The following is a description of a gene set: from publication Bedogni F, Hevner RF (PMID 34321999) Genes selectively expressed by postmitotic projection neurons in the cortical plate of embryonic day 14.5 mouse cortex. studied in species Mus musculus Mouse Gene Set: HEVNER_CORTICAL_PLATE_POSTMITOTIC_PROJECTION_NEURONS, and this is the list of marker genes: Atl1 (NCBI Gene Id 73991, atlastin GTPase 1), Cotl1, Rasgrf1, Vrk2, Ryr3, Ndrg1, Cdh13, Nsmf, Hs3st4 (NCBI Gene Id 628779), Sox5, Mgll, Ssbp3, Chst1, Lrrtm3, Tle4 (transducin-like enhancer of split 4), Abtb3, Lpl, Stx1a, Dmxl2, Sema4f, Dact1, Sgip1, Prkag2, Med13l, Sema4g, Ldb2 (LIM domain binding 2), Rab3d, Acvr1c, Nub1, Ppp3ca, Dab2ip, Herc3 (hect domain and RLD 3), Neto2, Kcna1, Tmem150c, Bach2, Rab3c, Ptpro, Rspo3, Adamts3, Ifngr2, Camk2b, Tmtc1, Scn2a, Fosl2, Ina, Tusc3, Nr4a3, St3gal1, Gria3, Rbfox1, Slc29a4, Hspa12a, Pde9a, Tenm2, Gls, Klhl29, Sh3gl2, Zfpm2 (zinc finger protein, multitype 2), Nrg3 (neuregulin 3), Spast, Gnal, Rnf112, Pcdh9, Ptp4a1 (NCBI Gene Id 98792), Rtn4r, Lrfn5, Adcy1, Cacna1h, Sema7a, Tgfbr1, Hs6st2, Marchf4, Khdrbs2, Rbm24, Dyrk2, Efna3, Smarca2, Lrrtm4, Kcnj3, Kcnv1, Fabp3, Kcng1, Rnf182, Fat4, Brd9, Cemip2, Fat3, Eps8, Cbln1, Baiap2, Asic1, Ppp1r16b, Lnx2, Cblb, Dync1i1, Kit, Syt4, Fig4, Trak1, Rtn4rl2, St18, Klhl8, Mgst3, Morn4, Adcyap1 (NCBI Gene Id 11516), Robo1 (NCBI Gene Id 436378), Sez6l, Pcnx1, Tnik, Sv2b, Slc8a1, Cnih3, Fbxo10, Hivep2, Tbc1d14, Neo1, Ttll1, Slit1, Bend6, Nab1, Trim9 (tripartite motif-containing 9, NCBI Gene Id 94090), Mdga2, Slc6a17, Nin, Tmod2 (NCBI Gene Id 50876), Itsn1, Slc1a1, Stk32b, Rabgap1l, Hecw1, Ablim1, Galnt17, Ppp1r1b (protein phosphatase 1, regulatory inhibitor subunit 1B), Akt3, Cacna1e, Ttc39b, Snap25, Nlgn1, Phactr1, Tspan5, Camk4, Elmod1, Tmem108, Sh3kbp1, Hpca, Gsg1l